Given this list of marker genes Ndrg1, Trib3, Pgk1, Tpi1, Eno1, Pdxp, Gpi1 (NCBI Gene Id 676974), Pfkp, Klf15, Ero1a (NCBI Gene Id 50527), Ehhadh, Klb, Scd3, Cbr1, Gapdh, Slc2a1, Cox7a1, Olr1, Higd1a, Egln3, Chchd10, Aldoa, Elovl3, Fgf21, Mrap, Rbp4, Gk, Igfbp4, here is a description of the gene set: Adipogenic genes (group 2) that are selectively repressed by SIRT1 in mature 3T3-L1 adipocytes. from publication Wang H, Qiang L, Farmer SR (PMID 17954559) species: Mus musculus Peroxisome proliferator-activated receptor gamma (PPARgamma) activity is regulated through association with ligands that include the thiazolidinedione class of antidiabetic drugs, as well as derivatives of polyunsaturated fatty acids. Induction of PPARgamma target gene expression involves ligand-dependent reconfiguration of the ligand-binding domain (LBD), followed by recruitment of specific transcriptional coactivators. In this study, we have identified an amino acid (F372) within helix 7 of the LBD that is required for the response of PPARgamma to endogenous ligands. Additionally, the data show that this amino acid is also required for expression of a novel subset of adipocyte genes (group 2), including fibroblast growth factor 21 (FGF21), and that the FGF21 gene is a direct target of PPARgamma. Expression of the group genes is selectively repressed by the NAD-dependent deacetylase SIRT1 in mature 3T3-L1 adipocytes, since knockdown of SIRT1 through the constitutive expression of a corresponding RNA interference enhances their expression without affecting the expression of classic adipogenic genes, such as adiponectin and FABP4/aP2. It appears that many of the group genes repressed by SIRT1 in mature adipocytes correspond to the same set of genes that are selectively activated by treatment of fat cells with the PPARgamma ligand, troglitazone. These data support a role for helix 7 of the LBD of PPARgamma in regulating adipocyte function and suggest that inhibition of SIRT1 in adipocytes induces the same insulin-sensitizing action as PPARgamma ligands. Mouse Gene Set: WANG_ADIPOGENIC_GENES_REPRESSED_BY_SIRT1